Given this list of marker genes TMEM123, TLE5, RNPS1 (RNA binding protein with serine rich domain 1), RPL9, EIF3M, RPL22, SEPTIN7, RPL4, ATF4, RPL23, SLC25A3, RXRB, NAP1L4, DEK, EIF4A2, EIF3F, ZBED1, RPL18, EIF3H, NONO, POLDIP3, CRLF3, RPL7, JUND, RPL27, FAM168B, PUM2, SNRNP200, KHDRBS1, RPL13, HSP90AB1, FAU, SARAF, SRSF11 (serine and arginine rich splicing factor 11), UQCRH, RBM5, ZC3H15, LSM14A, BRD2, DDX5, BRD8, NAP1L1, PTP4A2, RPL11, EEF1B2, BTF3, EIF3D, UBC, RPL14, PRPF8, RPS3A, HNRNPD, H3-3A, UBA2, ZFPL1, RPL31, ACTG1, RPL21, RPS27A, CASC3, RPS25, EIF3E (NCBI Gene Id 3646), NACA, TERF2IP (NCBI Gene Id 54386), DDX39B, SLC25A6, CCNI, ILF2, RACK1, FOXJ3, EEF2, PGK1, COX7A2L, RPLP2, CLCN7, RPL6, RPL19, TPT1, HNRNPH3, DRG1, EEF1G, RPS12, NCL, ACP1, YBX1, HNRNPK, CCDC28A (NCBI Gene Id 25901), YWHAZ, IK, HNRNPC, CALM2, ANAPC5, SUMO2, RPS24, XPO1, RPS7, IDH3B, LSM7, SDR39U1, COX7C, RPL34, UBB, UBE2I, HNRNPA1, RPL17, TIAL1 (TIA1 cytotoxic granule associated RNA binding protein like 1), NPM1, ARL2BP, GDI2, RHOA, RNF44, MYL6B, RPL10A, NSA2, EIF4G2, PUM1, SRSF2, OXA1L, DDX17, BRD3, ZNF384, DDX49, RPL24, RPL5, MACROH2A1, DNAJC8, TOP2B, ARPC3, RPS6, DAP3, RPL30, PPP2R5A, PCBP2, SNRNP70, YWHAQ, SRP14, SMARCC2, TERF1, here is a description of the gene set: Human Gene Set: MORF_EIF4A2 Neighborhood of EIF4A2 eukaryotic translation initiation factor 4A, isoform 2 in the MORF expression compendium studied in species Homo sapiens Neighborhood of EIF4A2